The following is a description of a gene set: Cytokines mediate cell-cell communication in the immune system and represent important therapeutic targets. A myriad of studies have highlighted their central role in immune function, yet we lack a global view of the cellular responses of each immune cell type to each cytokine. To address this gap, the authors created the Immune Dictionary, a compendium of single-cell transcriptomic profiles of more than 17 immune cell types in response to each of 86 cytokines (>1,400 cytokine-cell type combinations) in mouse lymph nodes in vivo. A cytokine-centric view of the dictionary revealed that most cytokines induce highly cell-type-specific responses. For example, the inflammatory cytokine interleukin-1β induces distinct gene programmes in almost every cell type. A cell-type-centric view of the dictionary identified more than 66 cytokine-driven cellular polarization states across immune cell types, including previously uncharacterized states such as an interleukin-18-induced polyfunctional natural killer cell state. studied in species Mus musculus from publication Cui A, Huang T, Li S, Ma A, Pérez JL, Sander C, Keskin DB, Wu CJ, Fraenkel E, Hacohen N (PMID 38057668) Mouse Gene Set: CUI_T_CELL_GD_M_CSF_RESPONSE_UP Genes positively differentially expressed in cell type: γδ T cell upon treatment with cytokine: M-CSF in mouse lymph nodes in vivo., and this is the list of marker genes: Itm2b, Cd82, Tor2a, Spcs2 (signal peptidase complex subunit 2 homolog (S. cerevisiae)), S100a11, Ltb4r1, Ldha, Rab5b (RAB5B, member RAS oncogene family), H2-T23 (NCBI Gene Id 15040), Chfr